The following is a description of a gene set: Chylothorax Accumulation of excessive amounts of lymphatic fluid (chyle) in the pleural cavity. studied in species Homo sapiens Human Gene Set: HP_CHYLOTHORAX, and this is the list of marker genes: CBL, FAT4, MAP2K1, BTNL2, BRAF, ADAMTS3, TSC1, HLA-DRB1, RASA1, TSC2, ALG14, PIEZO1, ACTA1, KIF11, FOXC2, PTPN11, CCBE1, EPHB4